Given this list of marker genes LMNB2, NUP214 (nucleoporin 214, NCBI Gene Id 9680), PPP1R21, TSEN15, TRAPPC12, LMNB1, EXOSC2, BICD2, MADD, AHDC1, STAMBP (STAM binding protein), GRIK2, TBCK, COPB2, TET3, here is a description of the gene set: Human Gene Set: HP_EXTRA_AXIAL_CEREBROSPINAL_FLUID_ACCUMULATION studied in species Homo sapiens An increased amount of cerebrospinal fluid (CSF) in the subarachnoid space. Extra-axial cerebrospinal fluid accumulation